Given this list of marker genes FGFR2, KIF11 (kinesin family member 11), NUSAP1, KIF4A, CCNA2, TOP2A, TTK, TCEAL9, EPRS1, PGK1, MKI67, PTGS1, ANLN, CCNB2, MAD2L1, CA2, CDKN2C, SCIN, PLK4, CCNB1, HS3ST1, KLHDC2, AURKA, ECT2, CIP2A, BUB1, PFKP, H2AX, SLC12A2, EIF4EBP1, KIF2C, RACGAP1, SLC7A5, here is a description of the gene set: species: Mus musculus Genes up-regulated in pre-B lymphocytes upon Cre-Lox knockout of E2A. Human Gene Set: GREENBAUM_E2A_TARGETS_UP from publication Greenbaum S, Lazorchak AS, Zhuang Y (PMID 15310760) The transcription factors encoded by the E2A gene have been shown to play essential roles in the initiation and progression of lymphocyte development. However, there is still a lack of comprehensive understanding of E2A downstream genes in B-cell development. We previously developed a gene tagging-based chromatin immunoprecipitation (ChIP) system to directly evaluate E2A target genes in B-cell development. Here, we have improved this ChIP strategy and used it in conjunction with microarray analysis on E2A-deficient pre-B-cell lines to determine E2A target genes in lymphocyte development. Both microarray data and ChIP studies confirmed that E2A directly controls IgH gene expression. The microarray assay also revealed genes that were significantly up-regulated after E2A disruption. ChIP analysis showed that E2A was most likely to be directly involved in repression of some of these target genes such as Nfil3 and FGFR2. An inducible E2A reconstitution system further demonstrated that E2A-mediated repression of Nfil3 and FGFR2 was reversible. Collectively, these findings indicate that E2A is a positive regulator for one set of genes and a negative regulator for another set of genes in developing B lymphocytes.